Given this list of marker genes PLA2G4E (NCBI Gene Id 388117), EHD2, COMMD1, SORL1, ACTN2, EHD1, AKAP5, ZDHHC2, EIPR1, here is a description of the gene set: studied in species Homo sapiens Human Gene Set: GOBP_POSITIVE_REGULATION_OF_ENDOCYTIC_RECYCLING Any process that activates or increases the frequency, rate or extent of endocytic recycling.